The following is a description of a gene set: Human Gene Set: GOBP_PROTEOGLYCAN_METABOLIC_PROCESS studied in species Homo sapiens The chemical reactions and pathways involving proteoglycans, any glycoprotein in which the carbohydrate units are glycosaminoglycans., and this is the list of marker genes: EDNRB, GNS, NDST2, CHST12 (carbohydrate sulfotransferase 12), B3GAT1, CHST8, ST3GAL6, HS6ST3, CHST11, EDNRA, B4GALT4, HS3ST6, FOXL1, MUSTN1, ADAMTS7, SLC2A10, UGDH, HYAL1, ADAMTS12, CHSY1, HYAL4, HGSNAT, TCF7L2, HPSE, TM9SF2, CANT1, HS2ST1, B3GAT2, B3GNT2, ST3GAL4, BMP2, BTK, DSE, EXTL1, IDUA (NCBI Gene Id 3425), HS3ST2 (heparan sulfate-glucosamine 3-sulfotransferase 2), EXTL3, CHPF, B4GALT7, GAL3ST4, NDST1, CHST7, HS3ST3A1, SULF1, B3GNT7, ST3GAL2, SLC35B2, CHST1, CHST14, HEXA, CSGALNACT1, BMPR1B, DSEL, SGSH, B3GALT6, BMPR2, ST3GAL1, CHST9, NDST4, SLC35D2, CHSY3, NAGLU, IGF1, UST, GPC1, COL11A1, XYLT1, CHST5, PPARD, CNMD, B4GAT1, CHST3 (carbohydrate sulfotransferase 3), SULF2 (NCBI Gene Id 55959), NDST3, B3GAT3, CYTL1, EXT2, GLB1, HS6ST2, SLC10A7, HS3ST3B1, CTNNB1, CHPF2, CHST10 (NCBI Gene Id 9486, carbohydrate sulfotransferase 10), HS3ST1, GLCE, CHST2, FAM20B, PXYLP1, CSGALNACT2, ADAMTS4, CHST6 (NCBI Gene Id 4166), B3GNT3, B3GNT4, COL2A1, ANGPT1, EXT1, HS3ST4, GUSB, CHST13, EXTL2, IDS, HS6ST1, HS3ST5, XYLT2, ST3GAL3, IHH, VANGL2, GAL3ST3, HEXB